The following is a description of a gene set: species: Mus musculus Mouse Gene Set: GOBP_DETECTION_OF_CHEMICAL_STIMULUS The series of events in which a chemical stimulus is received by a cell and converted into a molecular signal., and this is the list of marker genes: Or10ak11, Or5g25, Rtp2, Or6b13, Scarb1, Or1j21, Or12d13, Or2ag12, Or2y1, Or2d3, Or12k5, Tas2r140, Or10a2, Or10d4b, Pip, Or2y14, Or8a1, Or10g1, Or12e8, Or5p57, Or2n1e, Or2n1 (NCBI Gene Id 258829), Or13c25, Or2ab1, Or10a3m, Or2a56, Or10d1, Or5t9, Or2a57, Tas2r126, Or5p73 (NCBI Gene Id 258304), Or10g9, Or2ag1b, Or10u4, Or10d3, Kcnk3, Or4e1, Or5ar1, Or5p64, Or2aj4, Or2c1, Or10d4, Asic3 (NCBI Gene Id 171209), Calm1, Or2y1f, Or2z9, Or13c7b, Reg3g, Or10ag57, Or2h2c, Or2y3, Or5ap2, Or10al6, Or5p58 (NCBI Gene Id 258728), Or10a48, Or5p56, Or13f5, Or2w25, Or6b1, Or2n1c, Or6ae1, Or2t45, Tlr1, Or12k8, Or13d1, Or5an11, Or5an1b, Or2aa1, Or4e5, Or10g6, Tas2r113, Or2h15, Or12d16-ps1, Or2w2, Or2t29 (olfactory receptor family 2 subfamily T member 29), Or2b2b, Or10ad1, Or2ag1, Or12e14, Or2y16, Or2f2, Or2a54, Or2a5, Or2y10 (NCBI Gene Id 404336), Lpo, Or2y1d, Or2a20, Syt1, Or10al3 (olfactory receptor family 10 subfamily AL member 3), Nr4a1, Tas2r114, Or12j2 (olfactory receptor family 12 subfamily J member 2), Tas2r144, Or2l13b, Tas2r109, Or2w1b, Or13c7d, Casr, Kcnmb3, Or2g25, Or10ag59, Or12e1, Or2ag17, Or13ae2, Or2r3, Or12j5, Or2i1, Or5g26, Tas2r107, Or8u3-ps, Or1e16, Or2h1, Or8g18, Or10a4, Or2w3, Or2a7, Or9g19 (olfactory receptor family 9 subfamily G member 19), Tlr2, Tgfb3, Or2y13, Or2h2, Or10ak13, Or11m3, Or7a42, Or7e178, Or2o1, Or2ag2, Or2b11, Or5k16, Or13a1, Or2t35, Or5an10, Tas2r102, Gm7582, Or2y8, Or6k2, Or1j1, Tas2r104, Or2t48, Or2d2b, Or10n1, Rtp3, Tlr6, Kcnmb1, Or5h17, Or2ak4, Or2n1b, Or5t17, Or10ab4, Or10d5j, Or2a25, Tas2r105, Or2b28, Or4e2, Or5h19, Or7r1, Or2f1b, Tas2r118, Gucy2d, Pkd2l1, Or5p59, Or2bd2, Tas2r125, Or10h1, Or10j2, Or5an1c, Or10ak12, Kcnmb2, Gnat1, Or10ak8, Calm2 (NCBI Gene Id 75700), Or10g3b, Tas2r136, Or10ag52, Or5p53, Or10al7, Or5g29, Stim1, Or2k2, Or2y11 (olfactory receptor family 2 subfamily Y member 11), Or10a49, Or10ab5, Or2a14, Tas2r119, Or6k4 (olfactory receptor family 6 subfamily K member 4), Tas2r130, Or10al4, Or2t47, Or6n1, Tas2r110, Trpv1, Or2w1, Or10h1b, Or6p1, Or2w3b, Or2q1, Or10ag58, Or13p4, Tas2r121, Or5p80, Or13p10, Or2b4, Or2y12, Or5b21, Or5g9 (olfactory receptor family 5 subfamily G member 9), Plcb2, Or13g1, Or6e1, Or6a2, Or2y15 (olfactory receptor family 2 subfamily Y member 15), Or5d20-ps1, Or13e8, Or10am5, Or5p1, Or5p68, Or2ah1, Or8g50, Or12d2, Tas2r134, Or13j1, Or2ad1, Or5p60, Tas1r2, Tas2r117, Tas2r103, Tas2r120, Or10z1, Tas2r123, Rtp1, Or10w1, Or6k14, Tas2r131, Or2aj6, Or5p67, Or6aa1, Or2ag19, Or56b34, Or5p54, Or2y1e, Or2l13, Or2l5, Or8c8, Or2f1, Gnat2, Or2t26, Or5p62, Or10c1, Or10d1c, Tas2r115, Or2ag20, Or2aj5, Or2y6, Or10d4c, Or12d17, Or2n1d, Tas2r122, Or5p55, Or2g7, Trem2, Or2a51, Or2t49, Or1m1, Or10ag54, Tas2r138, Or2b6, Trpa1, Or5an1, Or10p1, Or4b13, Or4m1, Or2r2, Eng, Or5p69, Or10ak9, Slc24a4, Car6, Or10j27, Ryr2, Or5h18, Vmn2r1, Or2y1b, Or2r11, Or13p3, Or2z2, Or5an9, Or10a5, Extl3, Or2d3c, Or8u9, Or2g1, Or12d12, Or10ag2, Or9s13, Tas2r106, Pkd1l3, Drgx, Or2ak5, Tas2r137, Or1r1, Or2a12, Or5p4, Or5p51, Or2v1, Or2t6, Tas2r143, Or2d2, Or2ag13, Or10k2, Or5p70, Gm15433, Or13n4, Tas2r116, Casp4, Or5p66, Or12d14-ps1, Or2t46, Or2ag16 (olfactory receptor family 2 subfamily AG member 16), Or12j4, Or2m13, Or5p6, Or6n2 (NCBI Gene Id 258713), Itgav, Or10ak16, Tas2r124, Or2b2, Or2d36, Vmn2r26, Or10j3, Or5an6, Or12d15, Or10a3b, Or5p72, Tas1r3, Or10ak14, Or6b9, Clec7a, Or4c3d, Lbp, Or10u3, Or10aa3, Or10p22, Gm7609, Or2w6, Or10g7, Or8b3, Kcnmb4, Or10aa1, Or13c7c, Or12e9, Or10ad1b, Or6k6, Or2d3b, Or2ak6, Or10ac1, Or10ag60, Tas2r135, Or51e2, Or2ak7, Or10ah1-ps1, P2rx2, Or11i1, Or5v1b, Azgp1, Or2av9, Or10d1b, Or5p52, Or2a52, Ssc5d, Or2j6, Tas2r129, Or5p50, Or10al5, Or6z7, Or10j5, Or13p5, Or5m5, Or5p79, Or2j3, Or2t43, Or2t1, Or13c7, Or2y17, Or5t7, Tas2r139, Or10j7, Or10h5, Or2y1g, Or5t18, Or2p2, Sod2, Or7d11, Or2y1c, Tlr9 (toll-like receptor 9), Or10g3, Or2w4, Or10g9b, Or10j3b, Or2ag2b, Or13p8, Or5v1, Or2t44, Or10ag53, Or12e7, Tlr4, Ly96, Or2z8, Or3a10, Or6y1, Or10a3n, Tas2r108, Or12e13, Or2h1b, Or2ag15, Or10d5, Or8g17, Or10h28, Nod2, Or12j3 (olfactory receptor family 12 subfamily J member 3), Or7a40, Ffar4, Or5k17, Or8b8, Or10al2, Or2m12, Rtp4, Pigr, Or5p81, Calm3, Or2ag18, Or5j3, Or10g1b, Or10ak7, Or10ag56, Or10a3, Or10s1, Or2v2, Or5p76, Or2b7 (olfactory receptor family 2 subfamily B member 7), Or13c3, Or12e10, Or2d4